Given this list of marker genes CRP, CCL2, HBB, MPO, MTHFR, FGA, CBS, SAA2, ALB, ICAM1, PLAT, SERPINE1, MAT1A, SAA4, APOE, LRP2, IL6, SAA3P, SHMT2, IFNG, SAA1, FGG, SOD1, ABCA1, CUBN, APOB, SOD3, HBA1, F7, SOD2, RELA, LDLR, TCN2, IL1B, PLG, MTR, TCN1, INSR (insulin receptor), CCL5, SERPINA3 (NCBI Gene Id 95022), MTRR, INS (insulin), NFKB1, MCEE, NFKB2, CTH, F2 (NCBI Gene Id 14061), SCARB1, FGB, CBLIF, MMAB (metabolism of cobalamin associated B), APOA1, MMUT, TNF, here is a description of the gene set: studied in species Homo sapiens Vitamin B12 metabolism Human Gene Set: WP_VITAMIN_B12_METABOLISM